The following is a description of a gene set: Cytochrome P450 - arranged by substrate type species: Mus musculus Mouse Gene Set: REACTOME_CYTOCHROME_P450_ARRANGED_BY_SUBSTRATE_TYPE, and this is the list of marker genes: Cyp4f18, Cyp7b1 (NCBI Gene Id 99900), Cyp2c66, Cyp2e1, Cyp19a1, Cyp4v3, Cyp3a16, Cyp26c1, Cyp4f40, Cyp4b1, Cyp2c65, Cyp11b2, Cyp2a12, Cyp4a14, Nr1h4, Cyp2u1, Cyp2a22, Cyp3a41a, Cyp2c29 (NCBI Gene Id 13095), Cyp4a12b, Cyp4f39, Cyp39a1, Cyp27b1, Cyp11a1, Cyp4a32, Cyp4a30b, Cyp1b1, Cyp4a29, Cyp24a1, Cyp21a1, Cyp26a1, Cyp4a12a (cytochrome P450, family 4, subfamily a, polypeptide 12a), Cyp3a25, Ncoa1 (NCBI Gene Id 17977), Cyp3a57, Cyp4a10, Cyp26b1, Fdxr, Ncoa2, Cyp3a11, Cyp2f2, Cyp11b1, Cyp51, Cyp7a1, Cyp2w1, Ahr, Cyp4f15, Cyp2d22, Cyp3a41b, Cyp2a4, Cyp3a59, Arnt2, Cyp8b1, Cyp2s1, Fdx1, Fdx2, Pomc, Rxra, Cyp2a5, Cyp27a1, Cyp3a44, Cyp2b23, Cyp1a2, Tbxas1, Cyp3a13, Cyp2r1, Cyp4a31, Cyp1a1, Cyp46a1, Cyp4f14, Arnt, Ptgis, Ahrr, Cyp2j6